The following is a description of a gene set: Transient adhesive interactions between leukocytes and endothelial cells lining blood vessels. Carbohydrates on circulating leukocytes bind selectins on the vessel wall causing the leukocytes to slow down and roll along the inner surface of the vessel wall. During this rolling motion, transitory bonds are formed and broken between selectins and their ligands. Typically the first step in cellular extravasation (the movement of leukocytes out of the circulatory system, towards the site of tissue damage or infection). studied in species Homo sapiens Human Gene Set: GOBP_LEUKOCYTE_TETHERING_OR_ROLLING, and this is the list of marker genes: SELL, CXCL12, CHST4, GOLPH3, FUT7, EXT1, SELPLG, LEP, ELANE, CHST2, GCNT1, ST3GAL4, FUT9 (NCBI Gene Id 10690), CX3CR1, ITGB1, CCL28, JAM2, ROCK1, ITGB7, CCL21, ADD2, CCR2, TNF, SELP, CCL25, VCAM1, FUT4, SPN, SELE, PODXL2, ITGA4, MADCAM1